The following is a description of a gene set: species: Mus musculus Mouse Gene Set: GOMF_LIPID_PHOSPHATASE_ACTIVITY Catalysis of the reaction: a phospholipid + H2O = a lipid + phosphate., and this is the list of marker genes: Plpp4, Plpp7, Plppr3, Plppr4, Ephx2, Lpin3 (NCBI Gene Id 99277), Lpin1, Plppr2, Plpp5, Plpp3, Plpp2, Plppr1, Plppr5, Sgpp2, Plpp1, Lpin2, Sgpp1, Plpp6